Given this list of marker genes TMEM131, TEX10, KRAS, ANKRD46, ZNF81, EHD3, PDLIM1 (PDZ and LIM domain 1), NXPE3, SLC41A1, GPM6B, SUPT20H, TXNDC9, IFT25, AKIRIN2, KANSL2, NOSIP, SCRIB, GRK6, BCL9L, DCPS, NAB2, SNHG6, MIS18A, SLC26A11, EPHX1, SPRY1, CLNS1A, LIPA, FAM13B, PRKCA, RNF113A, POLR1F, CIPC, POGLUT2, NUTF2, MRPS30 (mitochondrial ribosomal protein S30), IL27RA, KPNA1, PFN2, ARID1B, C1orf52, CRK, AATF, SESN3, ST8SIA1 (ST8 alpha-N-acetyl-neuraminide alpha-2,8-sialyltransferase 1), INTS5, SH3BP5, INSIG1, RIPOR2, NAB1, RGS19, TMEM160, MAP3K1, PSMA6, RPS27L, RPS25, GRAMD4, SLC35E2B, ACACA, CNP, GPR83, METTL5, DDA1, TLR1, INPP5B, ZFP91, STARD5, C16orf54, TMEM9B, SH2D1A, C1QBP, CHD6, INPP5F, TMIE, VKORC1, COX18, MUL1, DIPK1A, IPO4, NDUFAF7, IL6ST, RPS19BP1, LGALS4, CFAP20, CCNT2, PTTG1, NR4A3, CCR7, ARHGEF18, FAAH, RNF19A, MRPS6, GPR146, CNOT7, SMCO4, MMD, SLAMF6, KLF2, FARSB, DCK, TSPAN13, PAG1, TGFBR3, IL21, YWHAZ, SYNPO, SLC25A22, SLC25A39 (NCBI Gene Id 51629), CYTH1, CUL2 (NCBI Gene Id 8453), FLNA, TOR1AIP2, APRT, EGR1, SEC14L1, TMEM223, PDCD1, CDON, ETF1, SLCO3A1, POFUT2, MORF4L2, TBL1X, POLR3H, SMAD4 (SMAD family member 4), STK4, CYTIP, IZUMO1R, MANEA, NPAS4, AVEN, AXIN2, SMPDL3A, DTX1, SUSD6, ZC3H12D, BLOC1S2 (NCBI Gene Id 282991), ABL2, HIBADH, PNO1, TCF7, F2RL1, HECTD3, ITM2A, VPS13A, EXOC7, BRI3BP, HSD17B11, PLEKHG2, RILPL2, FOXO1, CCDC86, IFIH1 (interferon induced with helicase C domain 1), KPNA4, SKIC8, ID3, HLA-DOB, CLIP1, FAM193A, NUFIP2, RBBP4, ST6GAL1 (NCBI Gene Id 6480), SLC2A4RG, POLR1D, SNX3, UBE2J1, TARBP2, MRPL40, ASCC2, ARID5A, TNFSF11, PLPBP, CZIB, MMGT1, ATIC, UBE2D2, PPIC, ANGPTL2 (angiopoietin like 2), PSMD8, SEMA4F, SKI, JPT2, RPL36A, AFF3, NAA10, TAF1C, GIT2, PIP4K2A, DECR1, ST3GAL1, IFT80, GRPEL1 (NCBI Gene Id 80273), GPATCH2, POU2AF1, WASF2, FAM149B1, NSG2, DYNLL1, MRPL41, here is a description of the gene set: Genes down-regulated in comparison of CD4 T cells from bone marrow versus those from spleen. Human Gene Set: GSE15733_BM_VS_SPLEEN_MEMORY_CD4_TCELL_DN species: Homo sapiens CD4+ T lymphocytes are key to immunological memory, but little is known about the lifestyle of memory CD4+ T lymphocytes. We showed that in the memory phase of specific immune responses to antigens, most of the memory CD4+ T lymphocytes relocated into the bone marrow (BM) within 3-8 weeks after their generation, a process involving integrin a2. Antigen-specific memory CD4+ T lymphocytes expressed Ly-6C to a high degree, unlike most splenic CD44hiCD62L- CD4+ T lymphocytes. In adult mice, more than 80% of Ly-6Chi CD44hiCD62L- memory CD4+ T lymphocytes were in the BM. In the BM, they are located next to IL-7-expressing VCAM-1+ stroma cells, and were in a resting state. Upon challenge with antigen, they rapidly expressed cytokines and CD154 and induced the production of high-affinity antibodies, indicating their functional activity in vivo and marking them as professional memory T helper cells from publication Tokoyoda K, Zehentmeier S, Hegazy AN, Albrecht I, Grün JR, Löhning M, Radbruch A (PMID 19427242)